The following is a description of a gene set: from publication Yu M, Li G, Lee WW, Yuan M, Cui D, Weyand CM, Goronzy JJ (PMID 22434910) Human Gene Set: GSE36476_CTRL_VS_TSST_ACT_72H_MEMORY_CD4_TCELL_OLD_UP With increasing age, the ability of the immune system to protect against recurring infections or to control chronic infections erodes. The objective of the current study was to identify gene expression signatures in elderly CD4 T cell responses Genes up-regulated in comparison of untreated CD4 memory T cells from old donors versus those treated with TSST at 72 h. species: Homo sapiens, and this is the list of marker genes: HGF, TKTL1, MOAP1, PHF11, C4BPA, NKTR, MCF2L, CYB561 (cytochrome b561), N4BP2L2, SLC2A3, HAO1, TTC17, GNAO1 (NCBI Gene Id 2775), SETD2, GALNT11, DAB2, IDS, OSER1, IL11RA, HTR1E, KAT6B, ZBTB20, NRSN2, NOMO3, RLF, TXNIP, SFTPC, USP3, CD69, UGT2B17, TBC1D5, PPP1CB, ZNF331, TSC22D3, HMHB1, IQSEC1, PCF11, GDPD5, NNMT, CEBPD, HOXC6, IGFBP3, NPBWR2, OVGP1, PCBP3, DAZAP2, LIPT1, INPP5A, EEF1D, CILP, PDK1, JAM3, MLLT11, RAP1GAP2, PLEKHA1, DLK1, ZBTB43, GFPT2, TLR3, MX2, ZFP36L2, ATG10, SEMA4C, TRPM3, PDZD8, ARL4A, IRS2, RIPOR2, RASGRP1, LARS1, SORL1, CPS1 (carbamoyl-phosphate synthase 1), PPP1R3A, RASGRP2, TOB1, ADGRE3, SCARB2, RGCC, ATMIN, RFPL3, PDZD2, FAM13A, SEMA3G, ATP6V1G1, EPHA4, SLC28A2, ARGLU1, NR4A2, JOSD1, NLRP3, ZNF236, SAR1A, ARHGEF3, PFN2, TIMP3, USPL1, NR3C2, MXI1 (NCBI Gene Id 4601), JUN, C1orf54 (NCBI Gene Id 79630), DCAF4, TUBA1A, C1orf115, CBFA2T3, THUMPD1, RPL23AP53, ACTR5, SMAGP (small cell adhesion glycoprotein), SPRY1, MADD, LEF1, CDK14, ADRA2A, PLCL2, PRPH, UBL3, CIRBP, MPPE1, PCDHGC3, CYP26A1, CXCR4, MATN1, BBOX1, KLF7, FCGRT (NCBI Gene Id 2217), CRY2, PTCH1, ZNF37BP, MAPK1IP1L, ZNF516, TRAM2, PLK3, LONP2, HIC2, GCGR, FPR1, NOL3, RPS29, ZNF395, GPRASP1, P2RX1, SIK1, CBFA2T2, KCNK15-AS1, NOS1AP, WNT7A (NCBI Gene Id 7476), ZNF136, LRIG2, STOM, CRCT1, SGK1, MNT, PPP1R2C, INSL4, RYK, GLYAT, SECISBP2, SRY, ADD3, SLC5A5, ACP3, CHN2, DNAJB1, IFITM1, ESRP1, ABO (ABO, alpha 1-3-N-acetylgalactosaminyltransferase and alpha 1-3-galactosyltransferase), TENT5C, LRIT1, ZNF529, DYRK2, REN, VAV2, TMX4, LINC00667, ITGB5, GABRB2, DUSP1, TCEAL2, FOS, MARCHF8, GSTK1, RAD52, PBX3-DT, FYB1, SLC16A10, YPEL5, ANXA1, ADAM22, FCHSD2, PSD3, S100A7, RPL34, HFE, TBC1D4, NME8, MYBL1, SLC2A9, DGKD